Given this list of marker genes CTNNB1, GNAQ, POLG, MT-TK, MTOR, MT-TW, MT-CO2, AKT1, SMO, TRAF7, MT-ND1, CEP78, TUBB2B, CDH23, CLRN1 (clarin 1), AKT3, MT-CYB, MT-CO1, SETD5, AARS1, TERT, MEN1, NF2, MT-TL1, SUFU, BAP1, MT-CO3, ADGRV1, BRAF, MYO7A (myosin VIIA), TREX1, SMARCE1, USH2A, MT-TV, MT-TF, MT-ND5, MT-TQ, PCDH15, PDZD7, PRORP, CIB2, USH1G, MT-ND6, WHRN, PDGFB, ESPN, AIP, SMARCB1, PIK3CA, MT-TC, HARS1, MT-TS2, EIF2B3, ARSG, GPR101, USH1C, AMACR (NCBI Gene Id 23600), here is a description of the gene set: Human Gene Set: HP_HEMIANOPIA species: Homo sapiens Partial or complete loss of vision in one half of the visual field of one or both eyes. Hemianopia